Given this list of marker genes CDH18, GNG5, CDH20, GNAZ (NCBI Gene Id 2781), PPP3CA, PDE4A, ARAP1, GNAQ, PIK3R1, STXBP1, CDH17, C1QC, PIK3CG, ZFYVE1, PCSK9, CDH10, FGF22, JAK1, CDH6, APC2 (NCBI Gene Id 10297), CUBN (NCBI Gene Id 8029), GNG14, GNAO1, AP2M1, GRIPAP1, PIK3C3, COQ8A, COQ7, SNAP91, CDH8, TGM3, COQ5, TOLLIP, SYN3, BECN1, CTNNB1, CTNNA2, CNKSR2, CDH11, BIN1, GNAT1 (NCBI Gene Id 2779), IRAK4, NRBF2, KALRN, GFRA2, COQ4, GNB3, PRNP, GNB1, CDH15, COQ2, SYN1, PIK3R4, FOLR3, GNA13, TYK2, GNG4, DNAJC6, GNG12, CDH22, JAK3, PIK3R6, JUP, CTNND1, PLEKHG4B, GNG13, COQ3, RPH3A, JAK2, GNAS, GNG10, UMOD, PLEKHG4, PIK3R5, CDH5, PIK3CA, GNGT2, CDH9, GNA15, GNGT1, STXBP5, PIK3CD (NCBI Gene Id 5293), ATP6V1A, CDH7, EMC2, GNAL, VWC2, GNAT3, KIAA1755, DCHS1, NOD2, GNB4, GNAT2, GNG8, PIK3CB, AKAP9, CDH2, PPP1R9B, GFRA1, GFRA3, ATP6V1H, MYD88, SARM1, GNA14, CDH23, UVRAG, CDH1, SCRIB, CDH24, COQ6, CARMIL2, CDH19, BECN2, TIRAP, ATP6V1B2, GNB5, ATP6V1D, CDH13, CDH4, TRAF6, CRKL, GNA12, CDH12, GNB2, PIK3R3, CDH3, ATP6V1C1, ATP6V1G1, TRIO, GNG7, FBXO2, AP2B1, CDHR3, GNG11, CNR2, ATP6V1G2, ATP6V1B1, GML (glycosylphosphatidylinositol anchored molecule like), GNA11, DOC2A, APC, C1QA, CNTFR, PIK3R2, ARHGEF40, GNG3, MCF2L, PICALM, GNAI3, DCD (NCBI Gene Id 79193), TRAF3IP2, GNG5B, GNAI1, CDH26, GNAI2, ARHGEF25 (Rho guanine nucleotide exchange factor 25), SNX10, FARP1, RNF10, PLAUR, BTBD8, ATM, CTNNA1 (catenin alpha 1), PLEKHA4, ATG14, DTNA, GNG2, here is a description of the gene set: Human Gene Set: GOCC_EXTRINSIC_COMPONENT_OF_MEMBRANE The component of a membrane consisting of gene products and protein complexes that are loosely bound to one of its surfaces, but not integrated into the hydrophobic region. studied in species Homo sapiens